Given this list of marker genes DUSP1, PRDM2, MYLK2, ARRB1, CYP19A1, SMAD7, KIF5C, CNIH2, PSMF1, WNK2, FOXJ1 (forkhead box J1), POLR3H, GHITM, BTBD9, XPO6, ZNF3, SLC24A4, NALF2, TMEM67, CRTC1, CADM3, IL6R, ASF1A, KMT2C, KCNH3, INTS6, ADGRG5, ASIC1, EFNA3, EI24, BRD2, ZNF780B, PDE7B, SPESP1-NOX5, ABCG1, PCTP, TMEM101, HIPK2, ZFHX3, ARL16, CCDC174, PTAFR, SSH2, C3orf18, KDM6B, GABARAPL1, PDP1, CGREF1, KDM2A (NCBI Gene Id 22992), NKIRAS2, AP4S1, GIT1, SETD4, OTUD3, DESI2, FAM131A, ZNF512B, POM121, STIP1, ETV4, HIC2, ADAMTS5, MTMR3, PHF19, NCDN, C22orf39, ESAM, HDAC11, DEFB132, TOMM40, VASP (vasodilator stimulated phosphoprotein), MSI2, SBNO1, SORCS3, CYGB, JAKMIP3, METTL21A, HHIPL1, NOX5, FYB1, ADIPOR2, ATAD3B, KCNAB2, CALR, PIK3R1, NMB, PLEKHO2, TMEM239, RAB11FIP4, CRELD1, SH2B1 (SH2B adaptor protein 1), ZSCAN23, AGAP1, INTS3, CARM1, WDR7, GIGYF1 (NCBI Gene Id 64599), CASQ1, SCML4, ALDH1A2 (aldehyde dehydrogenase 1 family member A2), WNK1, SPTB, TFB1M, PNMA5, HEATR6, TPPP (NCBI Gene Id 11076), PI16, CTNNA3, RXRB, NOP2, CYP4F11, HBP1, FOXP4, PRSS55, CCDC71L, HMGN3, TSFM, ADCY1, MTHFR, KIF3B, TMEM104, RIC1, BORA (BORA aurora kinase A activator), TMEM132C, RSPRY1, MYO1E, TRABD2B, ZNF500, TMEM249, GVQW3 (GVQW motif containing 3), TMEM178B, THSD7B (NCBI Gene Id 80731), RIMS4, ANKRD52, ATP11A, CASTOR2, LARP1, YTHDC1, AJAP1, GSE1, ANKS1A, ZNF25, BRWD1, LAIR1, EP300, here is a description of the gene set: Human Gene Set: MIR1913 studied in species Homo sapiens Genes predicted to be targets of miRBase v22 microRNA hsa-miR-1913 in miRDB v6.0 with MirTarget v4 prediction scores > 80 (high confidence targets). from publication Chen Y, Wang X (PMID 31504780)